The following is a description of a gene set: Human Gene Set: HP_LOW_GRADE_FEVER Mild fever that does not exceed 38.5 degrees centigrade. studied in species Homo sapiens Low-grade fever, and this is the list of marker genes: CD247, TET2, IL2RA, ANKRD55, IL2RB, JAK2, STAT4, CALR, MPL, PTPN22, PTPN2